The following is a description of a gene set: from publication Gracias DT, Stelekati E, Hope JL, Boesteanu AC, Doering TA, Norton J, Mueller YM, Fraietta JA, Wherry EJ, Turner M, Katsikis PD (PMID 23603793) Genes down-regulated in activated CD8 T cells: wildtype versus MIR155 knockout. MicroRNA-155 (miR-155) is upregulated in primary effector CD8 T cells but is expressed at low amounts in naïve cells. Anti-viral CD8 T cell responses and viral clearance were impaired in miR-155 deficient (bic-/-) mice, and this defect was intrinsic to CD8 T cells, as adoptively transferred bic-/- CD8 T cells generated greatly reduced primary and memory responses during infection. To understand the mechanism by which miR-155 regulates CD8 T cell activation, we analyzed the gene expression profiles of naive and in vitro activated wild-type and bic-/- CD8 T cells. Human Gene Set: GSE44649_WT_VS_MIR155_KO_ACTIVATED_CD8_TCELL_DN species: Homo sapiens, and this is the list of marker genes: CBR3, RFXAP, KIZ, CRYGB, ACP6, SEPTIN6, NOB1, SUSD3, TAF4, ARSG, LRRCC1, FLT1, TYW1, PTX4, RWDD2A, DKK3, GYS1, MCEE, FAM167A, GPR34, SYT7, NUDT6, ZNF157, SH3TC1 (NCBI Gene Id 54436), SYNE1, RAB19, RPL3L, DYM, ZNF746, TUBGCP6, GPN3, IRS1, CBY1, PES1 (NCBI Gene Id 23481), DNAI1, CXCR3, PDCD2L, CDH7, ACSBG2, P2RX7 (purinergic receptor P2X 7), PUS1, ICAM2, CD207, HEPACAM2, DPY19L1, SLC8B1, LPCAT2 (NCBI Gene Id 54947), CD226, DYNC1LI1, XKRX, TK1, ADCK1, TNNI2, AATF, PCDHB3, TRPC6, CLN3, PSPH, CMC1, ITPR2, RAPSN, CSMD3, CCR9, NDUFAF7, KLHL42, TAS2R1, TXNDC16, TSACC, GPX7, MRPS5, SLC4A7, TRIM23, PPM1K, PHYHIP, IMPA2, POLR1B, CD209, DNAJB13, AGPS, GRHPR, POLG, CEBPZOS, SRL, TENM4, TTLL4, LINC00511, RGS11, ZER1, UQCC3 (ubiquinol-cytochrome c reductase complex assembly factor 3), CEP104, FUT7, SERPINB8, HOMER2, AKAP10, TXNL4A, ANGPTL6, PCDHA11, FANCA, LMO2, RTL8C, AIRIM, UQCC2, HRG, PPM1F, HSD17B8, FUZ, MMP12, VSIG4, ZNF790, RSPH4A, SRGAP3, BPIFB3, EXOSC3, BST1, CNR2, PLPP2, RAMP1, BPHL, PRSS36, PRSS8, UBASH3B, NUP43, CYP2R1, NEK6, GARRE1, TUSC3, S1PR4, POLR3H, B4GALT4, WDR55 (NCBI Gene Id 54853), HLA-DMA, NADSYN1, MIGA1, STARD4, FCGR2A, POLA1, ACYP1, ATL1, GPR153, HOXA4, RPL32, ITM2A, CSGALNACT1, UNC119B, FUCA1, M1AP, ACVRL1, CASR, WDR76, RHOH, CFH, PSTPIP1, HK2, BDKRB2 (bradykinin receptor B2), SNHG12, ARL6IP4 (ADP ribosylation factor like GTPase 6 interacting protein 4), ADGRA2, LAT2, NANOG, ELOVL6, NME4, LIX1L, MCM3, ATXN1, TMEFF1, ZNHIT3, DNMBP, TM2D2, ARSB, RBM20, FFAR4, ARID2, SGSM2, ITGA8, ABCD2, XCR1, SLC5A8, EPHX1, RFTN2, ACOT13, PXYLP1, AKR1B10, ZNF764, SPATA13, KHK, MAS1, NELFA, HELB, KIAA0586, GP2, MBD4, UBAP1, KIF5A (kinesin family member 5A), FNDC7, FCRLA, DAPK2, EGR3, NPHP1, TXNDC5 (NCBI Gene Id 81567), CD37